The following is a description of a gene set: Human Gene Set: REACTOME_PROTEIN_METHYLATION Protein methylation species: Homo sapiens, and this is the list of marker genes: VCPKMT, EEF2KMT, METTL22, CALM1, METTL21A, ETFBKMT, ETFB, EEF1A1, EEF1AKMT2, RPS2, EEF2, PRMT3, EEF1AKMT1, CAMKMT, KIN, VCP, HSPA8